The following is a description of a gene set: Human Gene Set: MORF_BNIP1 Neighborhood of BNIP1 Neighborhood of BNIP1 BCL2/adenovirus E1B 19kDa interacting protein 1 in the MORF expression compendium species: Homo sapiens, and this is the list of marker genes: SLC33A1, SLC17A3, TBXT, GNPAT, IVL, AFF2, TENM4, NXPE3 (NCBI Gene Id 91775), OPRL1 (opioid related nociceptin receptor 1), MYOZ3, SSTR5, SULT2B1, GPATCH8, DNAJC16, CNKSR1, KRR1, BCL2, HSD17B3, IGKV7-3, PIAS2, CDYL, FUT6, TBX19, TMEM11, INPP5E, HOXD4, CACNB1, CA4, PRKACA, DOCK1, ZBTB14 (NCBI Gene Id 7541), PSG1, GSK3B, SLC16A5, ELAVL2, USP46, IFT27, COX6A2, FIG4, ARFGEF2, KHK, NOS2, PLEKHB1, RUNX2, ITIH4, SCAMP1, ABCB10 (ATP binding cassette subfamily B member 10), GLE1, RAD51D, P2RY10, KCNA5, S100A5, SLC18A1, CACNB2, ATP8B1, CDC73, FRYL, STK17A, GJB5, ESR1 (NCBI Gene Id 2099), LIG3 (DNA ligase 3), MC5R, ATP6V0A2, PGM3, MFN1, WBP4, BMP10, LPGAT1, ADCYAP1, KAT8, SLC30A3, PIK3CB, MLLT10, SURF2, OSBP, ADCY3, SLC6A11, NRTN, DGCR5, C1orf216, IL16, GRIP2, BRCA1, GPR19, KLHL18, ERC1, YAF2, TSSK2, IKBKE, RB1CC1, HNF1A, JRK, FOSL1, BRD1, WT1, FNTB, POU6F1, VKORC1, PAX9, NR1I2, FLT1, GTSE1, IL13, COL19A1, CCKAR, CYP2E1, PHF10, ZBTB22 (zinc finger and BTB domain containing 22), AOC4P, KRT86, HTR7, GRIK5, TIE1, POP4, SIM2, GPR15, DPT, MSX1, CLOCK, HTR4, MSL3, MAGEA9, PRELID3A, SLC22A6, MDM2, SULT4A1, IQCK, CYP11A1, ENTREP1, NPFF, AQP5, RXRG, PSMF1, CTRL (chymotrypsin like), EPHB2, EXTL3, NR2C1, ZNF134, ZNF500, PAXIP1, NTNG2, MSH3, RREB1, UBE4B, MYO9B, PTEN, ZNF592, TBX5, WIPF2, PPP1R1A, AQP7, ABO (NCBI Gene Id 28), HCRT, ITPR2, SLC2A1, AMMECR1, ZBTB40, NCKIPSD, PPP1R3D, TFDP2, DRC3, GPR18, PVR, SCAPER, PAX7, ZNF266, PIGB, CRHR1, SYT5, POLR2K, ZNF157, CASP10, SLC4A3, BNIP1, SGPL1, KRT2, RAP2C, SERPINA4, ABCC8, CYP2D6, ABCB9, ERCC4, LTBP4, TNFRSF25, KRT33A, BARX2, CD6, ARL3, CAMK2G, TBC1D22A